The following is a description of a gene set: Human Gene Set: REACTOME_RHO_GTPASES_ACTIVATE_KTN1 studied in species Homo sapiens RHO GTPases activate KTN1, and this is the list of marker genes: KTN1, KLC4, RAC1, KIF5A, RHOG, KLC1, KLC2 (NCBI Gene Id 64837), KLC3, KIF5B, RHOA, CDC42